Given this list of marker genes WBP11, TMEM209, AFF1, HNRNPH3, CFAP97, PCK2, BTLA, PANX3, SLC14A1, DHRSX, PTGER4, FILIP1L, EEF1E1, SLC1A4, RGS9, OLFM1, SIAH2, SLC7A1, TRIB3, SESN2, TRMO, OAS2, PPP1R15B, COPS3, GJB4, MORN4, PLCXD2, HSFY2, UMOD (uromodulin), MIA2, PIWIL4, UPF3A, MARCHF6, PGC, ZDHHC5, TRIM56, RELB, TTC39A, NTAQ1, CLK3 (CDC like kinase 3), PITPNB, LARS1, FIP1L1, NDFIP1, C15orf48, SPA17, VEGFA, HERPUD1, IAH1, ACR, ASNS, PSMB9, NAALADL1, LMO4, CEBPB, ZNF808, FGF11 (fibroblast growth factor 11), FRMD4B, SLC3A2, STX5, COQ5, ZNF516, CCR10, TMEM163, SARS1, SLC6A12, MLLT11, TMEM88, SLC37A1, GALNT16, ATXN7L1, NIPSNAP2, MPDU1, PAX6, P2RX4, ZNF622, ARPIN, KIT, ANAPC16, ACE2, SLC6A9, PQBP1, YPEL5, NFE2L1, SLAMF7, RHBDD1, KLF7, PRR11, SLC18A1, ZC3HAV1, TRAPPC6B, BANP, RBMX, STK40, MID1IP1, N6AMT1, ACKR2, ATF3, TAP1, PSPH, LRATD2 (LRAT domain containing 2), NMD3, GBP6, CHAC1, PYCR1 (NCBI Gene Id 5831), ST7L, CXorf49B, MAGEL2, IKZF4, INPP4A (NCBI Gene Id 3631), GPRC5D, C21orf91, CCDC115, SLAMF1, ZDHHC24, ATP11A, APOA1, TMEM11, TNFAIP8L2, AKIRIN2, FNDC3A, IFRD1, SERTAD1, BATF, PLXNB2, PNRC1, RALGAPB, HNRNPA1, DDIT4, MAFF, CBR4, COL26A1, LRP3 (NCBI Gene Id 4037), HAPSTR1, RASGRP1, EIF4EBP1, C2CD3, RBM4, SLC7A13 (NCBI Gene Id 157724), ZFP36, PDZD8, FERMT2, TMEM72, NEK8, FLT4, RAB2B, HTR1A, JUNB, ARL14EP, PTPN1, IRF1, MZT1, COX7A2L, TIMM22, ALDH18A1, NEMP1, H3-5, GBP7, MFSD6, ABHD10, ENSA, EIF2S2, NGDN, AFF4, GPT2, YPEL4, JDP2 (Jun dimerization protein 2), ARHGEF10, UBALD2, PHGDH, LYPD5, KHNYN (NCBI Gene Id 23351), KDM4A (NCBI Gene Id 9682), CLDN12, BNIP5, DDX6, PDCD1LG2, SLC7A5, MGAT4A, CEBPG, TMEM128, AARS1, NAB2, PHKG1, G0S2, TCTA, FBXO33, NSD3, ICAM1, EPC2, ATF4, VPS54, SLC38A2, DDIT3, YTHDF3, RHOG, FAM13B, SOCS4, CARS1 (NCBI Gene Id 833), GBP2, here is a description of the gene set: from publication Lund R, Aittokallio T, Nevalainen O, Lahesmaa R (PMID 14607935) Genes up-regulated in CD4 T cells: untreated (0h) versus activated by anti-CD3 and anti-CD28 and then stimulated by IL-12 (6h). studied in species Homo sapiens Human Gene Set: GSE2770_UNTREATED_VS_IL12_TREATED_ACT_CD4_TCELL_6H_UP Th1 and Th2 cells arise from a common precursor cell in response to triggering through the TCR and cytokine receptors for IL-12 or IL-4. This leads to activation of complex signaling pathways, which are not known in detail. Disturbances in the balance between type 1 and type 2 responses can lead to certain immune-mediated diseases. Thus, it is important to understand how Th1 and Th2 cells are generated. To clarify the mechanisms as to how IL-12 and IL-4 induce Th1 and Th2 differentiation and how TGF-beta can inhibit this process, we have used oligonucleotide arrays to examine the early polarization of Th1 and Th2 cells in the presence and absence of TGF-beta after 0, 2, 6 and 48 hours of polarization.